Given this list of marker genes UBQLN1, CALM1, PLN, CRHR1, GPR35, SUMO1, KCNE3, KCNAB1, CACNA1F (NCBI Gene Id 778), MMP9, OSR1, CBARP, TCAF2, KCNRG, GOPC, CALM2, KCNE1, ANK3, FMR1, CALM3, STK39, KCNQ1, SLN, GNB5, TLR9, KCNE2, GRP, here is a description of the gene set: species: Homo sapiens Any process that stops or reduces the activity of an ion transporter. Human Gene Set: GOBP_NEGATIVE_REGULATION_OF_ION_TRANSMEMBRANE_TRANSPORTER_ACTIVITY